The following is a description of a gene set: from publication Myllykangas S, Himberg J, Böhling T, Nagy B, Hollmén J, Knuutila S (PMID 16751803) Human Gene Set: MYLLYKANGAS_AMPLIFICATION_HOT_SPOT_18 species: Homo sapiens DNA copy number amplifications activate oncogenes and are hallmarks of nearly all advanced tumors. Amplified genes represent attractive targets for therapy, diagnostics and prognostics. To investigate DNA amplifications in different neoplasms, we performed a bibliomics survey using 838 published chromosomal comparative genomic hybridization studies and collected amplification data at chromosome band resolution from more than 4500 cases. Amplification profiles were determined for 73 distinct neoplasms. Neoplasms were clustered according to the amplification profiles, and frequently amplified chromosomal loci (amplification hot spots) were identified using computational modeling. To investigate the site specificity and mechanisms of gene amplifications, colocalization of amplification hot spots, cancer genes, fragile sites, virus integration sites and gene size cohorts were tested in a statistical framework. Amplification-based clustering demonstrated that cancers with similar etiology, cell-of-origin or topographical location have a tendency to obtain convergent amplification profiles. The identified amplification hot spots were colocalized with the known fragile sites, cancer genes and virus integration sites, but global statistical significance could not be ascertained. Large genes were significantly overrepresented on the fragile sites and the reported amplification hot spots. These findings indicate that amplifications are selected in the cancer tissue environment according to the qualitative traits and localization of cancer genes. Amplification hot spot 18: colocolized fragile sites and cancer genes in the 18q11.2-q23 region., and this is the list of marker genes: SMAD4, KDSR, MALT1, SS18, BCL2